The following is a description of a gene set: from publication Jeffrey KL, Brummer T, Rolph MS, Liu SM, Callejas NA, Grumont RJ, Gillieron C, Mackay F, Grey S, Camps M, Rommel C, Gerondakis SD, Mackay CR (PMID 16474395) In the present study we used Affymetrix oligonucleotide microarrays to produce gene transcription profiles for the major leukocyte types in humans. This comprehensive dataset enabled us to not only establish which genes were expressed in each leukocyte type, but also which genes were expressed in each subset after activation. The used of a comprehensive dataset of gene profiles from all the major human leukocyte subsets enabled a novel and powerful means for identification of genes associated with single leukocyte subsets, or different immune paradigms. studied in species Homo sapiens Human Gene Set: GSE3982_MAST_CELL_VS_BASOPHIL_UP Genes up-regulated in comparison of mast cells versus basophils., and this is the list of marker genes: CADPS, AP5S1, FCGR2A, TMEM223, TXNDC9, SLC2A5, STXBP2, MRPL35, RGS13, ST13, TOMM34, TAF11, UGGT2, C19orf53, IARS1, SLC30A1, CTNNAL1, WDR74, FGFR4, EPB41L3, QDPR (quinoid dihydropteridine reductase), ZPR1, SLC29A3, DUSP14, DBT, SOCS5, CTSL, ACTN3, BCKDHA, RLIG1, HNMT, RTN2, PVALB, MRM1, SLC16A2, DNAJC15, TGFB1I1, YWHAQ, ABCG5, ARL4A, CD101, AP3D1, SHQ1, MC1R, GGH, PGLS, PNMA1, CEP70, TEX10, H2AC16, CAMSAP2, TG, MTPAP, PLEKHG6, TCEAL9 (transcription elongation factor A like 9), SCN3A, STOM, CUL2, SLC12A8, ATP8A2, EIF3I (NCBI Gene Id 8668), STXBP1, HYOU1, GABRA2 (gamma-aminobutyric acid type A receptor subunit alpha2), ATG101, GFOD2, GFPT2, LINC01278, INSL4, MLXIP, SGK2, LPCAT3, SCLY, SEH1L (SEH1 like nucleoporin), AMIGO2, UBA5, PIP4K2B, MAPK6, EIF4A1, TUBB2A, CALM3, BPI (NCBI Gene Id 671), FPR3, HSPD1, ADI1, NPVF, ITGB1, RANGRF, SUPV3L1, F2RL2, CC2D1A, DNAH2, UBL4A, DSTN, SEC14L5, MEIS2, ERP29, AIMP2, P3H1, GTPBP4, MYO9A, DYRK1B, YBX3, HOXC11, ENO1, SPA17 (NCBI Gene Id 90953), NME1, ENDOD1, B4GALT5, DNAJB12, MIS12, ATP13A3, C1orf159, CCT3, MARCHF3, IQCA1, CERS6, FAM3C, PPP3R1, NFS1, FUCA1, RTL8C (NCBI Gene Id 8933), DPH2, PCOLCE (NCBI Gene Id 5118), TRIAP1, SERPINH1, TRAP1, COA1, TASOR2, GFOD1, AARS1, DPH5, VEGFA, MSANTD2, ANKRD40, AMHR2, OPA1 (NCBI Gene Id 4976), SEPTIN9, CFAP74, WDR12 (NCBI Gene Id 55759), MYH7B, CLNS1A, HSD17B12, TSC22D1, NRBP1 (nuclear receptor binding protein 1), TEX2, SLN, CMA1, PPT1, SORT1, LMNB1, DCTPP1 (dCTP pyrophosphatase 1), CLIP4, EIF2B3, VBP1, CAST, THBS3, PPP1R3A, PSMD12, MRPL4, NDUFB8, SHLD2, AKT3, ATG7, CYP11B1, ALDH1A1, CRLF2, STUM, AGTR2, FAM171A1, BFAR, HIGD1A, MAGEC2, WDR77, TMEM33, ESD, LINC00474, SPP1, PARK7, OTC, IL10, OLFML2B, TMEM8B, CTNND1, GRIN2A, RAI14, ABCF2, PRKAR2A, NQO1, MSMO1, PIGN, ANO10, TMSB15B, ELK4, RDH8, ESF1, NR0B1